The following is a description of a gene set: Genes predicted to be targets of miRBase v22 microRNA hsa-miR-4743-3p in miRDB v6.0 with MirTarget v4 prediction scores > 80 (high confidence targets). Human Gene Set: MIR4743_3P from publication Chen Y, Wang X (PMID 31504780) studied in species Homo sapiens, and this is the list of marker genes: STRN3, AKAP10, ZRANB1, ELFN1, RAPGEF6 (Rap guanine nucleotide exchange factor 6), ACTRT3, SORT1, RNF150, NDUFAF7, ZFP36L2, RAB3B, RIMS1, EFNB3, FAM227A, METTL15, BTBD9, GNA12, ZNF641, CMPK2, ARGFX, MFSD14B, NFYA, PKNOX1, GAD2, BPGM, KIDINS220, TAS1R3, DPY19L3, NFS1, ST8SIA4, FMOD, RAMAC, UHRF2, KAT6A, LRRIQ3, ZNF268, PCDH17, IFT22, TTC28, FGFBP3, ASB8 (ankyrin repeat and SOCS box containing 8), CNOT4, AK5, RPS6KB1, RIPPLY3, SLC29A1, STX6, PRKAR2A, PDE3B, ZBTB6, SMPD4, TMEM106B, GOLT1B, WBP2NL, RACGAP1, ZKSCAN1, XKR4, PRKCI, CPEB3, ARID2, RGS17, TNRC6B, PLN, NFIA, TRIQK, C9orf72, NAA16, WDR43, CHST9, DRP2, WWC2, PDAP1, CCP110 (centriolar coiled-coil protein 110), ZC3H12D, OPN5, SP100, SCUBE3, DMRTC2, TSPAN17, ACADM, GLRA2, SLC2A11, ZNF563, NUDT13, EPHA4, ZNF639, SH3TC2, MOSPD2, SP4, SKIDA1, TMEM18, EEA1, KLHL11, ABCE1, TRANK1, ZNF684, SLC30A4, AGTR1, PAFAH1B1, SLC38A1, SFMBT2, SS18, GGNBP2, SLITRK4, MGA, SGCD, TBC1D3, AFF4, MINDY2, CDH7, NTM, MINDY3, MAK, PLCL1, FBXO33, MINPP1, SIX1, SLC12A6, ZNF37A, ZNF287, GABRR1, EIF3J, SHISA9, CXorf58, HAPLN1, AIRIM, BCAT1, C15orf40, ZNF468, COG6, CDC7, TLL2, BTG2, RIOK3, SMIM10, PYROXD1, MYRIP, EEF1AKMT2, ADAM12, ZDHHC17, TNFAIP3, POU3F2, NSG1, C9orf153, MORF4L2, MYT1L, STK16, CNOT6L, PLAGL1, WDR33, ZBTB20, LAYN, PRKG1, LANCL2, IL15, GUCY1A2, CILK1, JMY, ANKRD29, ZNF462, FIGN, TBC1D3H, CPNE8, ERO1B, SLC30A7, SPCS2, DIP2B, EIF4H, ETNK1, ORMDL3, LIN54 (NCBI Gene Id 132660), TLE1, SIVA1, SELENOF, ZNF484, LRRC8C, FAM83B, ZNF35, LRRFIP2, TMEM47, GDNF, VASH2, PELO, ATP5F1A, ATF6, TRIM39 (NCBI Gene Id 56658), CYB5A, ZMYM4, NDEL1, RSPH4A, SLC19A4P, LVRN, RPF1, DUSP3, NAT8L, BDP1, LRATD1, L3MBTL1, CEP44, ASXL2, C17orf49, TECPR2, FAM169A, PSD3, ZNF652, CSF2, ATP11C, CIBAR1, RERE